Given this list of marker genes NRCAM, DLL4, ASL, PDHB, DOCK6, GTF2H5, NOTCH1, TBCK, ZFX (NCBI Gene Id 7543), CLCN4, RNU4-2, DDHD2, PC, CARS1, PDHA1, ESAM (NCBI Gene Id 90952), AFG2B, TET3, CTCF, AARS2, MORC2, TRMT1, AARS1, OPA1, ARHGAP31, FCSK, TARS1, LONP1, CDK13, NDUFC2, ERCC2, KDM5A, GTF2E2, NRROS, PRR12, RNF113A, SON, CNTNAP2, HK1, ARID2, PPFIBP1, EDEM3, USP7, RBPJ, MPLKIP, TPRKB, EOGT, PUF60, MPV17, ERCC3 (ERCC excision repair 3, TFIIH core complex helicase subunit), AMPD2, BRF1, AHDC1, here is a description of the gene set: Periventricular leukomalacia is characterized by diffuse injury of deep cerebral white matter, accompanied in its most severe form by focal necrosis. The neuropathologic hallmarks of PVL are microglial activation and focal and diffuse periventricular depletion of premyelinating oligodendroglia. Human Gene Set: HP_PERIVENTRICULAR_LEUKOMALACIA studied in species Homo sapiens Periventricular leukomalacia